The following is a description of a gene set: The multiplication or reproduction of epithelial cells of the submandibular salivary gland, resulting in the expansion of a cell population and the shaping of the gland. Mouse Gene Set: GOBP_EPITHELIAL_CELL_PROLIFERATION_INVOLVED_IN_SALIVARY_GLAND_MORPHOGENESIS studied in species Mus musculus, and this is the list of marker genes: Fgf10, Fgfr2, Il6, Tnf, Nkx3-1, Pdgfb, Shh